The following is a description of a gene set: species: Homo sapiens Regulation of receptor tyrosine kinase (RTK) activity is implicated in the control of almost all cellular functions. One of the best understood RTKs is epidermal growth factor receptor (EGFR). Growth factors can bind to EGFR and activate it to initiate signalling cascades within the cell. EGFRs can also be recruited to clathrin-coated pits which can be internalised into endocytic vesicles. From here, EGFRs can either be recycled back to the plasma membrane or directed to lysosomes for destruction.This provides a mechanism by which EGFR signalling is negatively regulated and controls the strength and duration of EGFR-induced signals. It also prevents EGFR hyperactivation as commonly seen in tumorigenesis.<br><br>The proto-oncogene Cbl can negatively regulate EGFR signalling. The Cbl family of RING-type ubiquitin ligases are able to poly-ubiquitinate EGFR, an essential step in EGFR degradation. All Cbl proteins have a unique domain that recognises phosphorylated tyrosine residues on activated EGFRs. They also direct the ubiquitination and degradation of activated EGFRs by recruiting ubiquitin-conjugation enzymes. Cbl proteins function by specifically targeting activated EGFRs and mediating their down-regulation, thus providing a means by which signaling processes can be negatively regulated.<br><br>Cbl also promotes receptor internalization via it's interaction with an adaptor protein, CIN85 (Cbl-interacting protein of 85kDa). CIN85 binds to Cbl via it's SH3 domain and is enhanced by the EGFR-induced tyrosine phosphorylation of Cbl. The proline-rich region of CIN85 interacts with endophilins which are regulatory components of clathrin-coated vesicles (CCVs). Endophilins bind to membranes and induce membrane curvature, in conjunction with other proteins involved in CCV formation. The rapid recruitment of endophilin to the activated receptor complex by CIN85 is the mechanism which controls receptor internalization. Reactome Pathway: EGFR downregulation part of: Signaling by EGFR, and this is the list of marker genes: HBEGF, SH3GL3, STAM2, PTPRK, CDC42, UBC, SH3KBP1, PTPN3, BTC, SPRY2, UBA52, ARHGEF7, SH3GL2, CBL, EGF, RPS27A, PTPN12, SPRY1, EPGN, AREG, EGFR, EPS15, HGS, SH3GL1, EPN1, GRB2, UBB, STAM, EREG, EPS15L1 (epidermal growth factor receptor pathway substrate 15 like 1), TGFA (transforming growth factor alpha)